Given this list of marker genes SAT1, USP36, CBLB, SNX11, EIF2AK3, ERF, TRIM29, EFHD2, SRD5A1, NTS, HSPB7, COL1A1, NPIPB3, FOLR1 (NCBI Gene Id 2348), EFNA1, ZZEF1, RHOBTB1, TST, BTG1, CLEC2B, PNN, PIM1, AGAP1, ZDHHC11, MAP1LC3B (microtubule associated protein 1 light chain 3 beta), EPHB4, ST7, DNAJB9, HERC1, RETREG2, HSPB8 (heat shock protein family B (small) member 8), LAMA5, KLHL24, ZXDA, ATF3, RPS21, RHOC, DKK1, PTBP2, PTTG1IP, ACYP2, GABARAPL1, TRGC1, P4HA2, IFRD1, PPP3CA, PTEN, MAP3K9, SAP30L (SAP30 like), UPF1, HOXC13, NR1D2, FOSL2, RARA, CREM, CDA, SMTN, ADGRG1, ST3GAL4, GSN, ZXDB, PPM1D, FAM53C, PATZ1, MAP7D1, H2BC5, SNHG32, EHD1, TXNIP, DDB2, CYP27B1, THAP9-AS1, ACKR3, KDM3A, CDKN1A, SNAI2, PEA15, VCPKMT, PILRB, ZNF767P, PDE2A, PRRC2B, NEDD4L, PLK2, CAMSAP1, TTC17, SPCS3 (signal peptidase complex subunit 3), FOXK2, NFE2L1, JUNB, FBXL18, TRIM52-AS1, ARL4A, ID2, BAMBI, GRK5, FRAT2, ARID5B, BRD2, PALLD, EPB41L4B, RBPMS, CTH, BAX, H1-2, WASHC3, TPM1, TRIB1, RIOK3, RYBP, SEC61A2, GADD45A, H2BC12L, CITED2, MSX1, FAM13B, SF3B3, RAB3GAP1, SOX13, ZMYM2, PFDN6, WASL, DYRK1A, SFSWAP, MTCL1, CPM, DNAJB6, DLG5, UROD, FAS, INPPL1, H2AC18, ZNF395 (zinc finger protein 395), GADD45B, FEM1C (NCBI Gene Id 84463), RNF44, SSX2, TNFSF9, MAPKAPK2, VPS37C, ELF4, MKNK2, MEX3D, RGS2, GPNMB, LXN, KHSRP, EFCAB14, PXDC1, SPAG9 (NCBI Gene Id 9043), CNPPD1, ELF3, DDR1, GPRC5C, HMOX1, PRDM4 (PR/SET domain 4), TMBIM1, FHL1, SLC35E3, OGA, H1-0, RNF13, ST6GAL1, PIK3R3, FMNL1, PHLPP1, RSRP1, PHLDA3, PCDH7, TFPI, PLPP3, ERAP1, SNAP25, NGRN, TRIO, DDX11, RASSF1, ATG14, ETS2, PPP1R12A, MEIS1, NDRG1, MDM2, ABTB2, TUFT1, POLG, FUBP1, GDPD5, RCAN1, KLF4, MTF2, RASSF9, RB1CC1, RTN2, CDKN1C, DNMBP, ADAMTS1, BMP6, RCBTB2, DENND3, HBP1, CDH10, ADAM17 (ADAM metallopeptidase domain 17), TNFAIP2, TUG1, INTS6, SH3GL2, PCNT, CPT1B, ADM, CCNF, CROCCP2, HEY1, WDR45, REPS2, KANK2, TRAFD1, TSC22D3, GNAS, HNRNPA3, DUSP5, TMEM87A, AMOTL2, ADCY9, SLC2A3, AXL, HIRA, KCNN4, HSPBAP1, UPP1, OTULINL, CANT1, RHOB, TIMP3, MN1, MBD1, SPTAN1, LIFR, TLE3, FRMD4B, JOSD1, ABHD3, STS, ZFTA, here is a description of the gene set: Genes down-regulated in HeLa cells after knockdown of MED1 by RNAi. studied in species Homo sapiens The TRAP/Mediator coactivator complex serves as a functional interface between DNA-bound transactivators and the RNA polymerase II-associated basal transcription apparatus. TRAP220/MED1 is a variably associated subunit of the complex that plays a specialized role in selectively targeting TRAP/Mediator to specific genes. Ablation of the Trap220/Med1 gene in mice impairs embryonic cell growth, yet the underlying mechanism is unknown. In this report, we identified distinct cell growth regulatory genes whose expression is affected by the loss of TRAP220/MED1 by RNA interference. Among the down-regulated genes revealed by cDNA microarray analyses, we identified Aurora-A, a centrosome kinase that plays a critical role in regulating M phase events and is frequently amplified in several types of cancer. In general, we found that TRAP220/MED1 expression is required for high basal levels of Aurora-A gene expression and that ectopic overexpression of TRAP220/MED1 coactivates transcription from the Aurora-A gene promoter. Furthermore, chromatin immunoprecipitation assays show that TRAP220/MED1-containing TRAP/Mediator complexes directly bind to the Aurora-A promoter in vivo. Finally, we present evidence suggesting that TRAP/Mediator is recruited to the Aurora-A gene via direct interactions between TRAP220/MED1 and the Ets-related transcription factor GABP. Taken together, these findings suggest that TRAP220/MED1 plays a novel coregulatory role in facilitating the recruitment of TRAP/Mediator to specific target genes involved in growth and cell cycle progression. from publication Udayakumar TS, Belakavadi M, Choi KH, Pandey PK, Fondell JD (PMID 16574658) Human Gene Set: UDAYAKUMAR_MED1_TARGETS_DN